The following is a description of a gene set: studied in species Mus musculus A cytoplasmic post-transcriptional gene silencing pathway in which piRNAs direct the cleavage of target mRNAs. The target mRNA, often transcribed from a transposable element, is destabilized by the activity of a PIWI class endonuclease within the piRNA-induced silencing complex. This may also be accompanied by mRNA deadenylation and decapping. Mouse Gene Set: GOBP_PIRNA_MEDIATED_GENE_SILENCING_BY_MRNA_DESTABILIZATION, and this is the list of marker genes: Gtsf1, Piwil1, Cnot7, Piwil2, Piwil4